The following is a description of a gene set: species: Mus musculus Post-translational protein modification Mouse Gene Set: REACTOME_POST_TRANSLATIONAL_PROTEIN_MODIFICATION, and this is the list of marker genes: Rara, Rora, Cog7, Mbd5, Fbxl19, Apol7e, Galnt14, Pcgf2, Polb, Sin3a, Apol11b, Usp11, H2ac7, Spsb3, Fbxo2, Adrb2, Dcun1d5, Muc16, Proz, Pomgnt2, Rab25, Fut8, Eif5a, Fbxl13, Adamts7, Bmi1, Rab4a, Fbxl4, Rnf123, Rpa1, Psmd12, Rnf168, Ykt6, H2ac15, Sumo3 (NCBI Gene Id 80474), Nfu1, Asb14, Stc2, Rps2, Galntl5, Rigi, Prmt3, Trp53, Pigc, Trappc3, St6galnac4, Tnc, Ggcx, Nup85, Cpm, Cul3, Rnf40, Bard1, Rab1a, Rccd1, Ttll8, Dcaf13, Pex2, Psmd6, Psme2, Mdc1, Rab32, Cops6, Psmc1, Rab17, Actr5, Psmd14, Sec31b, Uba1, Galnt7, Arf5, Senp8, Top2a, Rela, Klhl21, Psmb5, Nfkb2, Mpdu1, Nup205, Gm20716, Bap1, Cops4, B3gntl1, Sptb, Atxn3, Furin, Sec24d, Gpaa1, Rwdd1, Rab23, Plet1, Tuba3a, Il33, Usp29, Wdr48, Mfge8, Fbxw8, Kdm1b, Tuba1b, Tubb1, Rnf181, Ndufab1, Psmb3, H4c4, Ripk1, H2bc7, Mgat2, Thy1, Adrm1, Otulin, Calm1 (NCBI Gene Id 12313), Rab33b, Seh1l, Cdc73 (cell division cycle 73, Paf1/RNA polymerase II complex component), St8sia5, Galnt2, Jmjd4, St6gal1, Vhl, H2bc13, Trappc4, Slc35c1, Ppp6c, Manea, Cul2, Kbtbd8, Ep300, Hk1, Sptbn4, Ikbkg, Parp1, Nup42, Ogfod1, Pigl, Sbspon, Alg1, Csf1, Ubxn7, Ly6e, Alg2, Mbd1, Adamts16, Col7a1, Zranb1, Large2, Psmd11, Ctbp1, Wdr20, Psmc6, Gcnt1, Klhl42, Phc2, Glb1, Lypd4, Nudt14, Vdac2, Nup153, A4gnt, Cdc25a, Nans, Meltf, Rbx1, Calm3, Fbxw5, Ahsg (alpha-2-HS-glycoprotein), Trappc2l, H2bc12, Eef1akmt2, Commd3, Ccn1, Il6, Cand1, Rab18, Fuom, Wsb2, Alg9, Copg1, L3mbtl2, Foxl2, Mia2, Fbxo11, Ufd1, Pex10, Cntn5, Rps6, Rab20 (RAB20, member RAS oncogene family), Pten, Galnt11, St8sia6, Rad52, Rab5b (NCBI Gene Id 320645), Ube2z, Psg29, Eef2kmt, Thsd7b, Muc5b, Gorasp1, Gnpnat1, Klhl9, Thbs1, Pigp, Psmd8, Muc19, Slc35a1, Tpr (NCBI Gene Id 74816), Actb, Ano8, Pex13, Nup50, Josd2, Dync1i2, Rnf146, Dtl, Prkn, Dph3, Dcaf7, Ckap4, Actr8, Vcan, H4c6, Chst10, Usp47, Tulp4, St3gal1, Asxl1, Muc20, Tgoln1, Psme3, Psmd10, Rab3d, Ube2h, Rab35 (NCBI Gene Id 77407), Qsox1, Etfb, Rwdd2b, Ube2d3, Sdc2, Galnt13, Ttll5 (NCBI Gene Id 97844), Lipt2, C4b, Nup160, Lsamp, Cul4b, Leo1, Smad2, Ube2b, Rad23b, Galntl6, Socs6, Gm48551, Ercc8 (NCBI Gene Id 77046), Ly6h, Cops5, Ddb1, Rnf2, Arfgap1, Amelx, Rab7b, Kng2, Dnajc3, St8sia4 (NCBI Gene Id 20452), Thsd7a, Alg3, Mdm2, Nae1, Chst8, Napb, Galnt17 (polypeptide N-acetylgalactosaminyltransferase 17), Cop1, Dcaf5, Cops3, Lypd1, Stambp, Galnt16, Rxra, Psmb7, Foxo4, Usp10, Alg12, Tmem115, Usp16, H4c11, F8, Apol7b, Ddx5, Fbxl16, Adamtsl1, Prss21 (NCBI Gene Id 69448), Adamts20, Ino80c, Pgm3, Psmb4, Dda1, Adamts2, Prkcsh, Hdac7, Rps23, Man1a, Cnih3, Ctr9, Incenp, Usp9x, Bst1, Uba52rt, Babam2, Ddx17, Rab6a, Xpc, Asb18, Usp2, Eloc, Chm, Chml, Galnt10, Axin1, Map3k7, Rad23a, Btbd1, H2bc14, Dph5, Sec16b, Stag2, Spsb1, Cftr, Capza3, Rab14, Usp5, Trappc6b, Fem1c, Rab10, Wsb1, Ceacam1, H2ac23, Proc, Gfus, Asb17, Gas6, Nedd8, Npm1, Nup155, Dctn1, Skic8, Usp44, Ube2m, Rnf7, Ing2, Usp19, Ube2l3, Tnfaip3, Smad7, H4c12, Rnf152, Uba3, Dnmt3b, Ring1, Psmc5, Babam1, Uhrf2, Tnks, Sptbn5, Ppara, Rab39, Ar, Lman2, Fcgr4, Fuca1, Usp42, H2bc21, Nr3c2, Pcna, Dph6, Tubb2a, Traf6, Arfgap3, Usp37, Commd10 (NCBI Gene Id 69456), Usp20, Gata3, Fbxw9, B3gnt2, Ntm, Prss41, Bet1, Tuba1a, Alg14 (NCBI Gene Id 99754), Pomk, H2bc6, Fbxl8, Penk, Pros1, Ube2s, F7, Cetn2, Mysm1, Adamtsl3, H4c16, Muc15, H2bc24, Mettl21a, Tuba4a, Usp17la, Mgat3, Xrcc4, Gps1, Adamts1, Pex12, Hnrnpc, Ccna2, Rab7, Blm, Psma5, Cope, Fbxo17, Igfbp7, Sumf2, Rnf20, Dync1li1, Vcp, Lman2l, Tuba8, Rab8b, Skp2, Muc1, Smc6, Muc6 (NCBI Gene Id 353328), Chgb, Fn3krp, Nup58, Gpld1, Pcsk9, Smad4, Uchl3, Vcpip1, St6galnac2, Napg, Lgals1, Rab9b, H4c18, Fbxl20, Cdca8, Ptp4a2, Nr1i2, St8sia3, H2ac22, Dctn3, Fga, Renbp, Rab27a, Psg18, Fkbp8, Muc2 (mucin 2), Chst4, Usp7, Stx5a, Actl6a, Ttll6, Arf3, Dcaf11, H4c2, Eef2, Vnn1, Usp48, Tubb2b, Adamts5, Gfpt1 (glutamine fructose-6-phosphate transaminase 1), B3glct, Mrtfa, Ly6k (NCBI Gene Id 76486), Shisa5, Nr1h3, Sec22b, Ctsa, Fbxo7, Fem1b, Psma3, Nr5a2, Psmb1, F10, Ktn1, Psmg3, Nlrp3, Rab39b, Bglap2, Adamtsl5, Tubb4b, Elob, Fbxl15, Tectb, Ino80d, Reck, Sec22a (NCBI Gene Id 69021), Eef1akmt1 (EEF1A alpha lysine methyltransferase 1), Mitf, Smad1, Galnt15, Mepe, Spon1, Tab1, Akp3, Ly6g6c, Dync1li2, Rab24, Rab30, Actr10, Muc5ac, Suds3, Abraxas1, Stam2, Uimc1 (ubiquitin interaction motif containing 1), Npl, Gfpt2, Tfg, Fbxo32, Asb1, Cp, Psmd2, Ncoa1, Asb9, Thsd1, Lhb, Ttll7, Usp17lc, Asb4, Calr (NCBI Gene Id 12317), Ttll9, Rabggtb (NCBI Gene Id 19352), Rab2a, Serpina10, Mta1, Icmt, Rab3a (NCBI Gene Id 19339), Psmd13, Sptan1, Sec24b, Fbxw7, Ube2r2, Asgr1, Cd109, Psma1, Mgat1, Sec31a, Sparcl1, H4c3, H2bc8, Dcaf4, Serpinc1, Kctd6, Ube2e3, Tgfa, Cdc34 (cell division cycle 34), Atxn7, Nsmce1, Lmo7, Otub2, Mcrs1, Fstl1, Psmb6 (proteasome (prosome, macropain) subunit, beta type 6), Ttll4, Fbxo31, Rab44, Ctsc, Rab2b, Nanp, Nup93, Golgb1, Thbs2, H2bc1, H2bc15, Gosr2, Dph1, Calu, Art4, Etfbkmt, Pomp (NCBI Gene Id 66537), H2ac25, Ube2q2, B4gat1 (NCBI Gene Id 72430), Ube2i, Ino80, Sec13, Asgr2, Pigt, Arsb, Smc1a, Rab3c, Mbd6, Rab3b, Scg3, Uba52, Ube2f, Lias, Trp53bp1, H2bc9, Arf4, Otud7b, Lypd2, Serpina1b, Tbc1d20, Apol9b, Fbxw4, Fam20a, Pml, Tada3, Large1, Gcsh, Uap1, Gp2, Apoa1 (apolipoprotein A-I), H2ac10, Golm1, Glt28d2, B4galt4, Uchl5, Apoa2, Alg6, Mettl22, Nucb1 (nucleobindin 1), St3gal3, Prss23, Dcaf10, Rab40c, Ppp6r1, St3gal5, Nfe2l2, Psmd3, Plaur, Opcml, Sec24a, Nop58, Nup35, Cdc20, Gan, Ube2a, Fuca2, Ube2c, Izumo1r, Rabggta, Ttll3 (NCBI Gene Id 101100), Satb1, Rhoa, Lrr1, Hrc, Asb13, Lrrc41, Sec16a, Tecta, Kdm8, Wdtc1, Rnf128, Capzb, Psmg2, Umod, Pigs, Copg2, Copz1 (coatomer protein complex, subunit zeta 1), St3gal6, Dpm2, Spta1, Psma7 (proteasome subunit alpha 7), Aurkb, Rpl8, Fgg, H2ac6, Pigw, Suz12, Usp17le, Tmed7 (transmembrane p24 trafficking protein 7), Ttll10, Thrb, Apoe, Mpi, Esr1, Ube2t, Fbxl12, Kdelr3, Rab4b (NCBI Gene Id 75702), Fbxw11, St6galnac3, Psmd4, Rab26, Tomm20, Kctd7, St6galnac1, Apol11a, Areg, Rnf144a, Rab27b, Enam, Mgat4c, Ccdc22, Adamts17, Mdga1, Traf2, Rab31, Alb, Psmd9, Igfbp3, Ino80e (NCBI Gene Id 233875), Foxk2, Nsmce4a, Dolpp1, Wdr5, Man1a2, Ceacam2, Ttll11, Etf1, Fbxo44, Tubal3, Herc2, Amfr, Emid1, Cbx2, B3gnt8, Asb6, Sp100, Fbxo15, Apol10a, Pigh, Tmed3, Stambpl1, Rab29, Gcnt7, Asb12, Park7, Pmm2 (phosphomannomutase 2), Nr1h2, Nr1h4, Copz2, Socs3, Ngly1, Nrn1, Usp25, Commd1, B4galt6, Cd52, Vdac1, Cd59b, Mvd, Usp3, H2ac24, Cst3, Sptbn1, Rbbp5, Igfbp1, Usp24 (NCBI Gene Id 97161), Apol7a, Hif1a, Snx3, Igfbp5, Man1c1, Abraxas2, Dbt, Daxx, Spp2, Cmas, Rab9, Cga, Nup62, Pias2, Otud7a, Tdg (thymine DNA glycosylase), Sec24c, Tex101, B4galt2, Galnt18, Fbxl3, Prkdc (NCBI Gene Id 19090), Arsj, Psca, Adamts12, Ly6g6d, Spsb4, Tada2b, Psmd7, Thra, Becn1, Kdelr2, H4c14, Slc17a5, Otub1, Rab21, Socs5, Hipk2, Nup37, Cog8, Cnih2, Asb5, Fpgt, Camkmt, Vdr, Keap1, Nup214, Stx17, Cul1, Mmrn2, Fdx1, H2bc23, Muc17, Dcun1d3 (NCBI Gene Id 72260), H2ac19, Cyld, Arrb2, Nr3c1, Tnip3, Rad21, Piga, Rce1, Alg8, Usp18, Actr1a, Senp2, Galnt9, Tnip2, Gne, Muc21, Neurl2, Pdia6, Fbxl5, Sp3, Man2a1, Sae1, Pex5, F2 (NCBI Gene Id 14061), Tnks2, Serpind1 (NCBI Gene Id 15160), Rpl27a, Rab34, Mxra8, Fbxo27, Dmp1, Ogt, Ccp110, Tgfbr1, Pias4 (protein inhibitor of activated STAT 4), Usp33, Sptbn2, Alpl (alkaline phosphatase, liver/bone/kidney), Pdia3, Riox2, Lypd5, Smad3, Zc3h15, Uchl1, Ripk2, H2ac11, Trappc1, Nub1, Fbn1, Engase, Senp5, Rab36, Psmc3, Gbf1, Cntn3, St6gal2, Fbxw2, B3gnt4, Dolk, Skp1, Cops7b, Sumo2, Sumo1, Neu4, Uso1, Pom121, H4c8, Wfs1, Pigv, Brcc3, Dcaf6, Dync1h1, Fn3k (fructosamine 3 kinase), Pigg, Cnih1, Asxl2, Rab11a, Dctn2, Apob, Fbxo6, Pigf, Cops7a, Mia3, Klhl2, Bet1l, Hspa8, Nr5a1, Trrap, Dynll2, St3gal2, Ubc, Fem1a, Fbxw17, Rab33a, Rab40b, Otud3, Rab37, Chrdl1, Bpifb2, Adamts19, Galnt3, Nup54, H2ac8, H4c1, B3galnt2, St8sia2, Mcfd2, Nup210, Cdh2, Srd5a3, Nagk, Prnd, Ube2g1, Fbxl18, Folr2, Adam10, Tmed10, Dag1, Vcpkmt, Kat2a, Sema5a, Scg2, Stam, Adamts9, Nod2, H2ac4, St6galnac5, Drg1, Mul1, Ino80b, Man2a2, Dcun1d2, Fbxl14, Vwa1, Nsmce3, Hsp90b1, Dnmt1, Riox1, Axin2, Cd55, Aplp2, Ube2w, Dynll1, Kbtbd7, Megf6, Gpihbp1, H2bc3, Usp17ld, Cops2, Psme1, Nup133, Galnt12 (polypeptide N-acetylgalactosaminyltransferase 12, NCBI Gene Id 230145), Dnajc24, Psmb10, Pomgnt1, H2ac1, Dpm3, Preb, Scfd1 (Sec1 family domain containing 1), Galnt1, Cish, Rae1, Cog2, Rab38, Ube2d1, Mgat4b, Fbxl21, B4galt5, Mdm4, Satb2, Timp1, Rab1b, Ube2v2, Ccna1, Galnt5, Ins1, B4galnt2, Dcun1d4, Rab12, Bcl10, Adamts18, C3, Adamts10, Fut10, Foxk1, Dlat, Klhl13, Psme2b, Adamts4, Alppl2, H2bc11, Ttll12, Mgat5, Fn1, Ly6d, Klhl11, Trf, Usp28, B4galt3, B3gnt5, Arsi (NCBI Gene Id 545260), Asb7, Alpi, Mat2b, Gpc3, Calm2, Fbxo4 (NCBI Gene Id 67521), H2ac18, Stag1, Fbxl7, Rab5a, Tmed9, Sec22c, Rab8a, Tnip1, Cbx4, Ube2k, Kdelr1, Dph2 (NCBI Gene Id 67728), Pigm, Capza2, Traf3, H2ac21, Pgap1, Apol8, Nrn1l, Ube2n, Cog1, Fut11, Muc4, Pigu, Fbxo21, Fbxo10, Shprh, Arsa, Dpagt1, Nfkbia, Itih2, Hic1, H2ac13, H2ac20, Ube2d2a, Men1, Sec23ip, Usp34, Ikbke, Sec23a (SEC23 homolog A, COPII coat complex component), St8sia1, Pex14, Fam20c, Fgf23, Psmc4, Jmjd6, Tpst1, Nup43, Nsmce2, Kat2b, Dctn6, Serpina1c, Copb2 (NCBI Gene Id 50797), U2af2, Adamts14, Commd2, Josd1, H4c17, Birc2, Adamts13, Ppp6r3, Phc3, Sema5b, Ankrd28, Arcn1, Apc, Xpnpep2, Siah2, Fbxo22, Uba6, Kin, Asb10, Spon2, Pomt1, Smc3, Trappc5, Yy1, Tubb3, Mmrn1, Nup88, Gria1, Cops8, F5, P4hb, B3gnt3, Gmppb, Ube2g2, Cog3, Nrip1, Tmed2, Psmg4, C1galt1, Myc, Casp8ap2, Ubd, Pigq, Commd7, Csnk1d, Rab19, Klhl20, Arrb1, Dctn5, Fbxo9, Tfpt, Nup107, Nfrkb, Drg2, Gosr1, Wac, Commd9, Gcnt3 (NCBI Gene Id 72077), Adamts3, Sspo, Dcun1d1, H2bc4, Adamtsl2, Adamts6, Spaca4, Asb11, Neu2, Arsk, Birc3, Rab22a, Eef1a1, H4c9, F9, Dohh, Rraga, Cdk1, Adamts8, H2aj, Commd5, Pigz, Tmem132a, Dhdds, Apoa5, Cbx8, Napa, Alg5, Dlst, Ttll13, Klhl5, Gmppa, Lipt1, Epas1, Apol7c, Clspn, Ank1, Mgat4a, Usp13, Ndc1 (NDC1 transmembrane nucleoporin), Ankrd9, Usp26, B4galt1, Hcfc1, Usp17lb, Thsd4, C1galt1c1, Lypd8, Fbxw10, Ubb, Psmg1, Paf1, Sprn, Phc1, Dpm1, Ifih1, Aaas, Sumf1, Trappc6a, Rab15, Hif3a, Pnpla2, Rab43, Pigk, Nup188, Msln, Rangap1, Safb, Bmp15, Trappc10, Trim27, Cul4a, Ptrh2 (NCBI Gene Id 217057), Spp1, Negr1, Pign, Ambn, Vgf, Usp8, Derl1, Ubxn1, Folr1, Ctsz, Klhl41, Uba2, Psmc2, Hdac1, Cog6, Amdhd2, St3gal4, Neu1, Hltf, Rps27a, Top2b, Ttll2, Pias1, Adamtsl4 (NCBI Gene Id 229595), Ltbp1, Brca1, Dhps, Igfbp4, Rab13, B3gnt9, Muc13, Rad18, Zfp131 (NCBI Gene Id 72465), Dcaf8, Psma6, Otoa, Scmh1, Dcaf17, Fbxo40, Nod1, Pigyl (NCBI Gene Id 66268), Cog5, Jmjd7, Adamts15, Commd6, Bmp4, Socs2, Pigx, Psmb11, Apol9a, Copa, Gmds, Pmm1, Ranbp2, Top1, Psmd5, Psg22, H2ac12 (NCBI Gene Id 319168), Tuba1c, Dctn4, Trappc9, Psmb8, Fbxo41, Ruvbl1, Copb1, B3gnt7, Matn3, Senp1, Eid3, Psma2, Nus1 (NUS1 dehydrodolichyl diphosphate synthase subunit), Psmb2, Psmd1 (proteasome (prosome, macropain) 26S subunit, non-ATPase, 1), Usp22, Galnt4, Amtn, App, Golga2, Usp21, Gcnt4, Lypd6b, Rtn4rl2, Eif5a2, Asb16, Galnt6, Smurf2, Usp15, Pomt2, Arf1, Pigb, Nsf, Hgs, Sar1b, Commd8, Commd4, Neu3, Spsb2, Rbbp7, Kbtbd13, Taf9b, Asb8, Nploc4, Ube2e1, Ide, Tubb6, Trappc2, Pofut2, Btbd6, Pgr, Tomm70a, Rab6b, Fstl3, Arfgap2, Afp, Fcsk, Rab5c, Lman1l, Smc5, Taf10, Topors, Rcn1, Psma4, H2bc22, Ccnf, Nup98, Rhot1, Arsg, Hnrnpk, Usp30, Usp4, Usp12, Rab11b, Lman1, Klhl3, Klhl22, Mbtps1, Dync1i1, Usp14, Art3, Hdac4, B3gnt6, Klhl25, Yod1, Vdac3, Pias3, Canx, Ddb2, Tpst2, Tuba3b, Tubb4a, Lypd3, Cog4 (NCBI Gene Id 52332), St6galnac6, Notum, Sts (NCBI Gene Id 20905), Apol10b (apolipoprotein L 10B), Cfp, Fbxo30, Tfap2c